The following is a description of a gene set: Any process that modulates the frequency, rate or extent of the synaptic vesicle cycle. species: Mus musculus Mouse Gene Set: GOBP_REGULATION_OF_SYNAPTIC_VESICLE_CYCLE, and this is the list of marker genes: Casp3, Cdk5r1, Rab3b, Dnajc5, Syn1, Bsn (bassoon), Slc10a4, Scrn1, C9orf72, Snap29, Ppp3r1, Rapgef4, Nrxn1, Pls3, Arhgdia, Lpar1, Prkar1b, Pld1, Psen1